The following is a description of a gene set: Mouse Gene Set: MIR_6340 from publication Chen Y, Wang X (PMID 31504780) species: Mus musculus Genes predicted to be targets of miRBase v22 microRNA mmu_miR_6340 in miRDB v6.0 with MirTarget v4 prediction scores > 80 (high confidence targets)., and this is the list of marker genes: Pde1c, Tmem131, Setx, Mosmo (modulator of smoothened), Pcsk7, Hs3st3a1, Cst5, Jph1, Glb1, Virma, Rc3h1, Tab3, Nsd1, Nucks1, Esrrg, Ywhab, Zfp971, Itgb8, 1700102P08Rik, Srgap2, Mtmr3, Esr2, Abca13 (ATP-binding cassette, sub-family A member 13), Ppp6c (protein phosphatase 6, catalytic subunit), Slc9a9, Atg4d, Sirt3, Nmur2, Jade2, Naa30, Lpar4, Ercc3, Sorbs1, Frat2, Mcts1, Jmjd4, Zmat4, Lcn2 (NCBI Gene Id 99344), Col5a1, Nmt1 (N-myristoyltransferase 1), Smarcad1, Gdnf, Proser1, Cttn, Them4 (NCBI Gene Id 75778), Zfhx3, Cert1, Kdm2a, Mtm1, Zfand3, Bsnd, Usp9x, Kbtbd2, Lmo4, Irf2bp2, Galnt1, Baz2a, Ppargc1a, Elk3, Pakap (NCBI Gene Id 97198), Errfi1, Dll1, Phf6, Irs4, Tbc1d19, Gpd1, Rasa1, Trim33, Gcc2, Dolpp1 (NCBI Gene Id 93794), Snx12, Psip1, Pag1, Tmem248, Klhl28, Mtnap1, Slc16a1, Sh2b2, Clcn3 (NCBI Gene Id 12725), Srrm4, Spata13, Pgf, Pym1, Tmem154, Slc2a1, Arrdc3, Fign, Mapk8, Ino80d, Prr14l, Cdkl4, Atp2a2, Hmg20a, Ccdc96, Naa15, Cdh11, Foxo1, Tubgcp4, Sall4, Ackr2, Slc8a1, Ppip5k1, Fbln5, Rubcn, Map1b, Tmem100, Sulf1, Tasor, Asph, Bcl11b, Cpd, Nars2, Rabl3, Bnip3, 1600012H06Rik, Gm14295, Kcnip1, C9orf72, Btaf1, Raver1, Ccdc6, Dicer1, Gm57858, Dzank1, Kcnc2, Tomm22, Gpr156, Srsf6, Ube4a, Cldn19, Hipk1, Gnaq, Serinc5, Elovl5